The following is a description of a gene set: Human Gene Set: GOMF_CERAMIDE_TRANSFER_ACTIVITY species: Homo sapiens Removes a ceramide from a membrane or a monolayer lipid particle, transports it through the aqueous phase while protected in a hydrophobic pocket, and brings it to an acceptor membrane or lipid particle., and this is the list of marker genes: PLEKHA8P1, GLTPD2, PLTP, CPTP, GLTP, MTTP, CERT1, PLEKHA8